Given this list of marker genes IFNGR1, YPEL2, ZNF337, ZBTB18, UST, PARP10, NOTCH2, HERC6, RNF44, DDX60, VAV3, ZNF419, SLC39A10, IFITM3, FNDC3A, SLC25A30, IL13RA1, ZNF274, SETX, HLA-A, CD69, DUSP1 (dual specificity phosphatase 1), PNRC1, CISH, ADAM28, UBE2W, CSNK1D (NCBI Gene Id 1453), ENC1, ITM2B, PLEKHO1, CD47, CD63, LYST, TSPYL1, CHD1, HHEX, GARS1-DT, IL16, TNFSF12, GSAP, CCR6, ZMYND11 (NCBI Gene Id 10771), MYO1F, IFIT2 (NCBI Gene Id 8375), IFI16, SLC66A2, CFAP97, FXYD5, CAMK1D, MAX, ABCB4, EFEMP2, NT5E, TGFB1, GABBR1, SETD1B, CD55, TGFBR2, PLOD3, HK2, DTX3L, TMEM150A, SELL, CD72 (CD72 molecule), PLEKHA1, ARHGAP15, MAN2B1, MAP3K1, PECAM1, INO80D (NCBI Gene Id 54891), TRIM44, AUTS2, CHD2, PLCB2, RPL27, RAB37, BTLA (B and T lymphocyte associated), DPY19L1P1, CBX7, ZFP2, PRR12, DGKA, ENSG00000280119, FCER2, RPL7A, TRIM38, LAIR1, PLP2, ZBTB10, GAPT, LIMD1, ZNF862, ZBP1, MIR600HG, GPR183, RIN3, BTN3A3, FAM117A, ZSCAN18, ADAM8, CHML, CTNND1, RPSA, LYL1 (NCBI Gene Id 4066), FCGR2C, ANTXR2, NBPF10, RGS19, VPS37B, BTN3A1, RHOF, KLF2, BMI1, DOCK10, MSN, ROR1, FHIP2B, CYTH4, CCDC50, TOP1MT, CHD7, MAML2, PRKD2, DCTD, PSTPIP1, OPN3, PATL2 (PAT1 homolog 2), STAT1, PDE4B, MYO7B, EMP3, CLEC2B, PMEPA1, SLC25A24, SPRY1, NR4A2, CEACAM1, MACF1, CD46, IRF9, LY6E, ARAP2, PSMB9, HEXD, SKI, N4BP2L1, SNX18 (sorting nexin 18), RBMS1, RPL30, CAST, SHISAL2A, IFFO2, CR1, DPH5, RPS6KA5, CASP1, GOLGA8A, RP9P, RXRA, ZNF41, MLLT6, BTN3A2, SAP30L-AS1, L3MBTL3, VPS13C (vacuolar protein sorting 13 homolog C), HES1 (NCBI Gene Id 3280), LINC00205, GALNT2, TRMT61A, LHB, SHFL, ABCA17P, SLC18B1, MOB3B, CD83, GVINP1 (NCBI Gene Id 80073), APPL1, ARHGAP27, ESYT1, ABCB1 (ATP binding cassette subfamily B member 1), JAM3, KDM4B, SLC12A6, HEXB, MARCHF3, ANKRD11, TXNIP, DYRK2, LARGE2, ITPK1 (NCBI Gene Id 3705), CHKB, CTC1, CARINH, ZNF559, PARP9, here is a description of the gene set: Sorted B cells using flow cytometry. CD19 selected B cells were sorted using flow cytometry. Genes down-regulated in comparison of germinal center B cells versus naive B cells. Human Gene Set: GSE12366_GC_VS_NAIVE_BCELL_DN from publication Longo NS, Lugar PL, Yavuz S, Zhang W, Krijger PH, Russ DE, Jima DD, Dave SS, Grammer AC, Lipsky PE (PMID 19023113) species: Homo sapiens